The following is a description of a gene set: species: Homo sapiens Genes containing one or more binding sites for (ATXN7L3) in their promoter regions (TSS -1000,+100 bp) as identified by GTRD version 20.06 ChIP-seq harmonization. Human Gene Set: ATXN7L3_TARGET_GENES from publication Yevshin I, Sharipov R, Kolmykov S, Kondrakhin Y, Kolpakov F (PMID 30445619), and this is the list of marker genes: HLA-DMA, CDH22, TPT1-AS1, SNORD60, ACTB, PRKCE, RNVU1-28, HM13-AS1, SQSTM1, CEBPB-AS1, PRSS22, CCDC97, C19orf48P, THEM6, ISL2 (ISL LIM homeobox 2), ALG5, STC2, USP36, TXNRD1, OIP5-AS1, HSD17B7P2, RPS20, MIDN, ENSG00000275765, TMEM68, OLMALINC, SLC3A2, SNHG29, CFAP97, DYNC1LI1, MIX23, ZFP36L1 (NCBI Gene Id 677), CCNP, NUDT19-DT, UCA1-AS1, REEP3, EIF2AK1, ELF3, ATP13A3-DT, VAPA, CBX4, SLC20A1, PDP1, CTNNB1, URGCP, SARAF, SEMA7A, SMAGP, TNFRSF12A, ZFP62, TSEN15, MARK2, MAGT1, SOX9-AS1, PKMYT1, KLF2-DT, MTUS1, ELF3-AS1, ERRFI1-DT, DKK1, MIR1302-3, GCH1, HSPA5-DT, HNRNPD, HSPA8, PRKCZ, TIMM44, TRIB1, BCOR, ARHGEF11, HERPUD1, SRRM2, ENSG00000254531, RUNX1, ESYT2, VEZT, FOSL1, C11orf68, LINC02585, PNRC1-DT, SLC20A1-DT (NCBI Gene Id 400999), PICART1, USP22, SVIL, UGDH-AS1, PRNP, PTMA, NUDT19, SNHG1, ARHGAP10, SNHG12, VPS26C, CPEB2, PAQR4, LTBP4, NR1D2, POLM, DNAJB11, YWHAE, PEX3 (NCBI Gene Id 8504), CDCA7L, DLX4, H2AZ2-DT (H2AZ2 divergent transcript), RPS5, HSPE1, SETD5, MBD6, SLC7A11, ARID2, ITPRID2-DT, ENSG00000273162, MFF, C17orf75, ARHGAP12, ZBTB4, CAV1, DLGAP1-AS2, ATP13A3 (ATPase 13A3), WDPCP, SNORA16A, ADAP2, MIDEAS, MAP3K5, SLC9A3R1-AS1, USP32, ABR, RPLP1, S100A10, SNORD49B, GBA1, SMIM14-DT, CASC3, SNX9, LINC02028, NT5M, C15orf39, SHARPIN, RNU11, LINC01719, ITPRID2, GARS1-DT, ZNF827, GLUD1, TMEM250, PDXK, CBX3, SCRIB, ASNS, SRRM2-AS1, LUC7L2, RNU5E-1, FRMD6, TBC1D14, BRD2, MTUS1-DT, MTF2, KMT2E, MALL, RNVU1-21, PNPLA8, CDC73, KLF4, UBE2D4, NFS1, HNRNPH1, MARF1, THAP5, TRIM8, PDIA3, GAPDH, LRRC37A3, RCOR1, MIR4492, MID1IP1-AS1, ACP7, ZBTB5, C10orf95-AS1, MTRFR, SLC16A3, EPN3, SYVN1, LDLR, KMT2A, MET, GDI2, CERS2, GADD45B, KRT18, GPRC5A, NOTUM, H3-3B (NCBI Gene Id 3021), STKLD1, RAI1 (NCBI Gene Id 6600), THUMPD3-AS1, SLC25A45, NF2, MIS12, MCL1, MAML3, PIM3, OTUD7B, RP9P, IQANK1, GATD1-DT, TLK2, DMGDH, TRAF7, HNRNPD-DT, MNAT1, STK40 (NCBI Gene Id 83931), NFAT5, BRWD1, GSE1 (Gse1 coiled-coil protein), YARS1, NFIL3, LGALS1 (NCBI Gene Id 3956), CYB561, ATG10, KIF23, G3BP1, ANKRD11, TRIOBP (TRIO and F-actin binding protein), VCP, JAK1, SOWAHC, CALR (calreticulin), IMPACT, ZNF367, MIR1538, DUSP4, RPL13A, BHLHE40, IER5L, KAZALD1, TPT1, APBB2, MIR616, RC3H2, MAN1A2, JRK (Jrk helix-turn-helix protein), GEMIN7, NDE1, ZNF143-AS1, CANX, DNAJB9, RNF166, SNORD26, H2AZ2, SYDE2, GZF1, STIP1, COMMD10, MST1P2, CIC (capicua transcriptional repressor), ENO1, SMURF2P1 (NCBI Gene Id 107133516), FLOT1, SLC35D2, NOXA1, RABGGTA, LINC01145 (long intergenic non-protein coding RNA 1145), VRK2, GTF2IRD2B, PRDM4, HSD17B12, CPNE7, ANKRD40, NOP56, POLR3B, MFF-DT, NXN, CCN1, POLR3G, LDHA (NCBI Gene Id 3939), PKM, PSAT1, MAFF, BAG6 (NCBI Gene Id 7917), SPATA2L, ZBTB37, H3C12, TMEM50B, PLEC, ANXA4, STAU2, TOB2, ZFAND6, PPM1D, MIR5702, TBCCD1, GADD45A, SELENOS, RCC1, CATSPER2P1, NRSN2-AS1, ANXA2, RPLP0, ZBTB25, SELENOK, NOP14-AS1, ARHGEF19, CRELD1, MIRLET7BHG, MIR3143, ITSN1, ICA1-AS1, MAF1, HRK, SNORD68, CSRNP2, RAB6A, SLC39A14, PARP2, HOXA9, DUSP28, TBL1XR1, CTU2, DNAJB2, H4C1, KCNAB2, RPL13, RPS3, DST, DDX19B, B3GALT4, RNVU1-6, DDX5, MKNK2, PPP1R9B, CYP24A1, MIR762HG, PYCR1, RPPH1, SIL1 (NCBI Gene Id 64374), FBXL6, FBXL4, PAM, CTNNA1-AS1, MDH1, CLK1, CROCCP2, RBCK1, AREG, MPHOSPH9, ACSF3, CTSB, DDIT3, SMIM14, KLF2, IQCH-AS1, SREBF2, ZFP36, HNRNPAB, SLC33A1, EEIG1, METTL15, DEK, ANKLE2, CHD2, APIP, PNRC1, ARIH1, ENSG00000266401, F2RL1, IGF2BP3, LRP5L, SNORA78, FOXO3, TRIM65, NR3C1, ASAP1, TTC41P (NCBI Gene Id 253724), MARK4, DPY19L4, TGS1 (NCBI Gene Id 96764), MIR4530, CELSR3, ZBTB1, OTOP2, MIR7845, WDR31, CEBPA-DT, DENND1A, EREG, CALM3, IRF2BP2, RESF1, KRTAP5-AS1, ZNF696, USH1G, MINPP1, SNHG9, SEPTIN10, TBC1D19, SEC61A1, FAM174C, CD55, EXOSC4, ANKRD10, OSR2, RBM39, ENY2, SEMA3C, HSPA5, STX18, PPP3CA, SESN2, SNORD54, CEBPA, BMP4, EGR1, PCTP, RAB33B, ATAD2, CLDN6, POLR2A, ZNF34, REX1BD (NCBI Gene Id 55049), PDF, RCN1, AIG1, MIR4754, ERRFI1, OGT, GADD45GIP1 (GADD45G interacting protein 1), INTS6-AS1, PFN1, ATG12, ZNF217, CERNA3, KRT23, MLEC, MIR3190, H2BC17, SPG7, EEF1A1, GLI2, SLBP, HSPD1, ATP2A2, SNHG19, LINC01569, SMARCD2, IMPDH2, ID3, IRAG1-AS1, ZKSCAN2, TMEM202-AS1, H2BC12, MIR4664, RDX, SPATA1, HES1, H2AC6, DUSP8, EXOSC6, SREBF1, SFR1, GULP1, GARS1, SORBS3, CEP95, C15orf61, S100PBP, DERL2, XBP1, DDOST, PCK2, EEF2, RAB11FIP2, DLGAP1-AS1, KLF7, MAP2K3, MTHFD1L, NQO2-AS1, TRMU, PTPN14, PDIA6, HMGA2, H2BC5, MIR5188, TEFM, ANXA3, MARCKSL1P2, TTI2, MSTO2P, TXNDC11, ABHD11, XPOT, CUTC, MIR378D2HG, MTAP, PPP5D1P, IER5, MFSD3, HSP90B1, ITGB4, SCAF8, TRIP4, DDX59, BCL3 (BCL3 transcription coactivator), ITPRIPL2, PRKCZ-DT, EIF4A1, EHD2 (NCBI Gene Id 30846), ITGA3, NUDCD1 (NudC domain containing 1), RNF141, RAB11FIP1, SNORD27, LINC01775, HOXA10, HP1BP3, POLDIP3, REXO4, HMGA1, POLR3C, ZMYM4, GAS5 (NCBI Gene Id 60674), JMY, GPX4, MIRLET7I, HNRNPF, GORASP2, MYO1C, STX18-AS1, MYO6, KIF23-AS1, HNRNPU, UGDH, ING1, ANXA11, INTS1, NQO2, GEM, PITPNC1, HYOU1, HSD17B7 (NCBI Gene Id 63064), SGK3, ENO3, RNF115, MIR4519, KRCC1, LINC00963, EDC4, MYOF, IRS1, CHCT1, LSM14B, SNRPD2, LINC02983, SLC38A2, SURF4, AP3S1, CUX1, HSPE1-MOB4, NEAT1, TRIM8-DT, PPIB, CITED2, GALNT7-DT, CTNNA1, RHOBTB3, TMEM198, MIR5087, SPAG9, ENO1-AS1, ARAP2, LARP1B, TSC22D1, TUBA1C, NDRG1, SMG8, SIPA1L1, SET, RTN4, EXD3 (exonuclease 3'-5' domain containing 3), MIR6821, CORO1C, SLC52A2, MCM3AP, ATF3, RPS2, MALAT1, ACTG1, H2BC26, CARS2, ARL4A, TACO1, ZBTB45, ROMO1, STEAP1B, PDE4B, RPL3, YBEY, IMMT, ARHGDIA, HSPA9, ADAMTS14, RHOB, SNX25, SNORD49A (NCBI Gene Id 26800), LINC02901, DUSP16, DECR1, LURAP1L-AS1, CAPN3, S100A6, SRC, VEGFA, LRRC8B, VPS36, SNORD15A, FASN, C14orf93, SHROOM3, CDC42BPA, FUT8, MEMO1, P4HB, UBE2D2, ENSG00000263011, ZNF143, CHMP6, GLG1, RPL14, PLEKHH3, GSK3A (glycogen synthase kinase 3 alpha), EXTL3, ZFAND5, ADAT2, SNORD25, FAT1, MBLAC2, UBC, BOLA1, CTBP2, ATF4 (NCBI Gene Id 468), PLEKHG1, DNAJB4, H1-10, H2AC17, PSCA, MFSD10, CPEB2-DT, CFL1, HMGCS1, COX15 (cytochrome c oxidase assembly homolog COX15), FAM162A, GCLC, ACOT11, QPCTL, EIF4A2, HSPA1B (NCBI Gene Id 3304), LINC02960, YTHDC2, SPRED1, CASC2, PCLAF, AP1S3, BEND6, ICA1, GATD1, INTS6, SNORD43, LRRC14, FNDC3B (fibronectin type III domain containing 3B), SNORD3A, TEAD1, NPHP4, PXN-AS1, PDHX, PRKG1-AS1, RNF43, PHIP, CHPF, PALD1, KBTBD2, ADM, CYCS, CRYZL1, ADGRG6, TUBB2A, NR4A2, UBE2S, STARD4, CALM1, FGD6, LNCOC1, FOXK2, DRAP1, SNHG5 (NCBI Gene Id 387066)